Given this list of marker genes TOP2A, PARP15, PSORS1C1, LAMA3, SNX20, NCKAP1L, GBP2, PLK2, MSR1, FOXE1, FCGR2B, FNDC1 (fibronectin type III domain containing 1), HLA-DRA, NLGN4X, APOL1, IRF4, CCR4, HLA-DPA1, DTL, MAP2, LPAR5, SLITRK2, LTB, UBASH3A, CNR1, IGF1, FAM110C, TASL, MELK, ADAMTS14, GAPT, LY9, ABCC3, THEMIS, UGDH, SELPLG, EOMES, GZMH, TTK, NCAPG, SEMA5B, JAKMIP3, CDCP1, RAB3C, GPR65, RAB27B, CD38, P2RY13, GAL3ST4, TRIM16L, RHOH, GPRIN1, CCL5, IKZF3, LILRB1, ARL4C, GPR85, GAS2L3, GBP1, LRRN4, C1QC (complement C1q C chain), CLIC2 (NCBI Gene Id 1193), FASLG, here is a description of the gene set: Fumarate hydratase-deficient renal cell carcinoma (FH-deficient RCC) is a rare yet highly lethal kidney cancer. To deepen understanding of FH-deficient RCC, the authors conduct a comprehensive integrated genomic study. The authors analyze the association of FH alteration patterns with tumor heterogeneity and develop a CpG site-specific methylation signature for precise identification of FH-deficient RCC. Transcriptomic analysis unveils three distinctive molecular subtypes characterized by enrichment of immune/Angiogenic/Stromal (C1), WNT/Notch/MAPK (C2), and proliferation/stemness (C3) pathways, respectively. Tumors in C1 derive the most substantial survival benefit from a combination of immune checkpoint blockade (ICB) and anti-angiogenic therapy. Tumors in C2 display moderate response to this therapeutic approach. In contrast, tumors in C3 exhibit an unfavorable response to anti-angiogenic monotherapy and its combination with ICB. These findings contribute to a profound understanding of the aggressive nature of FH-deficient RCC, offering insights into potential precision medicine approaches for disease management. from publication Zhang X, Zhao J, Yin X, Liang J, Wang Y, Zheng L, Tan P, Lin Y, Xu N, Zhu S, Chen J, Zhao J, Hu X, Pan X, Nie L, Zhang M, Chen Y, Zhang Y, Liu H, Dai J, Wang Z, Liu H, Ni Y, Rupp NJ, Moch H, Sheng X, Gong K, Liu X, Chen Z, He Z, Wang Y, Xu L, Liu M, Zhou H, Tang B, Huang R, Wei Q, Li X, Liu J, Yao J, Liao B, Liu Z, Shen P, Chen N, Zeng H, Sun G (PMID 40355427) Genes upregulated in FH-deficient RCC tumors compared to adjacent normal tissues. Human Gene Set: ZHANG_FH_DEFICIENT_RCC_TUMOR_VS_NORMAL_UP studied in species Homo sapiens